The following is a description of a gene set: The cytoplasm of an ovum. species: Homo sapiens Human Gene Set: GOCC_OOPLASM, and this is the list of marker genes: PADI6, NLRP5, SCAPER, FAF1, TLE6, KHDC3L, OOEP